Given this list of marker genes HTR2B, HTR4, HTR2A, HTR2C, SLC6A3, HTR1F, SAT1, AMD1, SATL1 (spermidine/spermine N1-acetyl transferase like 1), HTR1A, HTR3A, HTR1B, HTR1E, SLC6A4, here is a description of the gene set: Binding to an amine, a weakly basic organic compound that contains an amino or a substituted amino group. Human Gene Set: GOMF_AMINE_BINDING species: Homo sapiens